The following is a description of a gene set: Mouse Gene Set: GOBP_POSITIVE_REGULATION_OF_EMBRYONIC_DEVELOPMENT Any process that activates or increases the frequency, rate or extent of embryonic development. studied in species Mus musculus, and this is the list of marker genes: Zbed3, Nlrp4f, Utp25, Nlrp5, Otx2, B4galt5, Wnt4, Pafah1b1, Cfl1, Osr1, Scx, Osr2, Rbm19, Khdc3, Rack1, Hspa5 (NCBI Gene Id 99198), Lhx1, Foxa2, Amot, Plcb1, Wnt1, Tenm4 (teneurin transmembrane protein 4), Tle6, Nr2c2, Wnt3a